Given this list of marker genes IPP, PIGL, PKD2L1, FUT1, SERPINB7 (serpin family B member 7), CFAP44, BTG3, H1-1, FZD5, TSNAXIP1, S100A11, SLC16A2, LPCAT2, PARP8, LTBR, OLFM4, SLC9A6, ASAP2, CARF, PDE10A, ZFP36L1, MAK, AIG1, KCNJ1, EAF2, COMMD4, MAP7D3, CRYBG1, CPA1, DMRT1, ZNF608, SLC38A3, ZBTB3, MINK1, PCIF1, B3GNT5, SLC38A2, CLN5, KRT35, LMAN1L, PCYT1A (phosphate cytidylyltransferase 1A, choline), CAMSAP2, TRMT1, PSME4, PBX4, SRSF12, MLC1, SLC7A5, OSBPL10, ASPSCR1, SPATA31A7, IQGAP1, YJU2, ACSL3, ALDH3A1, PRKG2, KLRA1P, S100A10, BFSP2-AS1, TGM1, HAGHL, SLC10A1, DLGAP3, NOD2, RAPSN, PTK7, MT1X, TMEFF2, XPR1, ANKRD2, HRG, FABP3, KATNAL2, HOXB2, FBN3, RNF133, CEBPB, HYAL3, SCPEP1, M1AP, SLC9A1, CTAGE1, CD226, RNASE2, here is a description of the gene set: species: Homo sapiens Human Gene Set: MODULE_341 Genes in the cancer module 341.